Given this list of marker genes METAP1D, RCAN3, PSMB9, CCR10, NFIA, ANKRD13A, ANKFY1, PLEKHG7, CDK1, UST, TMEM177, LIAS, DCAF5, PHACTR2, OCRL, FKBP1B, RAPGEF5 (Rap guanine nucleotide exchange factor 5), AEBP2, MOCS2, EFNA5, CEP44, FAM81A, MRFAP1L1, LDB1, SRSF1, ADAR, DLX5, CYFIP1, RUNX2, BID, RPL7L1 (NCBI Gene Id 285855), NSG1, ZEB1, MTMR9, EIF2S3, here is a description of the gene set: Genes predicted to be targets of miRBase v22 microRNA hsa-miR-2114-5p in miRDB v6.0 with MirTarget v4 prediction scores > 80 (high confidence targets). studied in species Homo sapiens from publication Chen Y, Wang X (PMID 31504780) Human Gene Set: MIR2114_5P